The following is a description of a gene set: D-loops generated after strand invasion and DNA repair synthesis during homologous recombination repair (HRR) can be resolved through Holliday junction intermediates.<p>A D-loop can be cleaved by the complex of MUS81 and EME1 (MUS81:EME1) or MUS81 and EME2 (MUS81:EME2) and resolved without the formation of double Holliday junctions, generating cross-over products. All steps involved in this process have not been elucidated.<p>Alternatively, double Holliday junctions can be created by ligation of crossed-strand intermediates. Double Holliday junctions can then be resolved through the action of the BLM helicase complex known as BTRR (BLM:TOP3A:RMI1:RMI2). BLM-mediated resolution of Holliday junction intermediates prevents sister chromatid exchange (SCE) between mitotic chromosomes and generates non-crossover products. SPIDR enables recruitment of the BTTR complex to the ionizing radiation-induced foci. The complex of FIGNL1 and FIRRM, which, through FIGNL1, simultaneously interacts with SPIDR and RAD51, may facilitate the function of SPIDR in promoting the no cross-over route of homologous recombination repair. Mitotic SCE can result in the loss-of-heterozygosity (LOH), which can make the cell homozygous for deleterious recessive mutations (e.g. in tumor suppressor genes). Double Holliday junctions can also be resolved by cleavage, mediated by GEN1 or the SLX-MUS complex (composed of SLX1A:SLX4 heterodimer and a heterodimer of MUS81 and EME1 or, possibly, EME2). The resolvase activity of GEN1 and SLX-MUS predominantly results in crossover products, with SCE. species: Homo sapiens part of: Resolution of D-Loop Structures Reactome Pathway: Resolution of D-loop Structures through Holliday Junction Intermediates, and this is the list of marker genes: RBBP8, RAD51D, TOP3A, RAD51AP1, DNA2, MRE11, NBN, BRCA1, BRIP1, KAT5, BLM, FIRRM, BRCA2, RMI1, EME2, SLX4, RAD51, PALB2, WRN, ATM, RMI2, XRCC3, SPIDR, GEN1, XRCC2, RAD50, SLX1A, RAD51B, BARD1, SEM1, EXO1, EME1, RAD51C, FIGNL1 (NCBI Gene Id 63979), MUS81